The following is a description of a gene set: Mouse Gene Set: MIR_384_5P studied in species Mus musculus from publication Chen Y, Wang X (PMID 31504780) Genes predicted to be targets of miRBase v22 microRNA mmu_miR_384_5p in miRDB v6.0 with MirTarget v4 prediction scores > 80 (high confidence targets)., and this is the list of marker genes: Ifi213, Htr4, Tcaf3, Dnmt3a, Smad1, Ppargc1b, Lox, Pnkd, Gpcpd1, Fnip2, Zfp521, Trappc14, Ssx2ip, Camkk2, Ccdc71l, Gigyf2, Macroh2a1, Ubn2, Ago1, Gnai1 (G protein subunit alpha i1), Rfx7, Rundc3b, Cracdl, Rasgef1a, Ror1, Kctd8, Tcstv2c, Capza1, Csnk1g1, Pdcd5, 0610040J01Rik, E2f7, Arid5b, Bmp5, Gnai2, Kmt2c, Tepsin, Prdm1, Myo5a, Dlgap4, Tmod2, Il21r (NCBI Gene Id 60504), Tnrc6a, Hic2, Zdhhc21, Rnf157, Trip12, Mlxip, Mcf2l, Camk2d, Usp45, Gria2, Sh3rf1, Samd4 (NCBI Gene Id 78475), Pcnx2, Rbm44, Fkbp3, Brd10, Ddah1, Septin7, Tbc1d30, Ankhd1, Cthrc1, Map6, Rad23b (RAD23 homolog B, nucleotide excision repair protein), Sel1l3, Nadk, Gmeb1, Marchf4, Osbpl8, Sall4, Maml1, Sh2b3, Hnrnpul2, Psmd7, Mier3, Hdac9, Ino80d, Frzb, Cdh20, Mfsd6, Dio2, Tdg, Snx33 (NCBI Gene Id 235406), Cadm2, Usp47, Chd1, Rab15, Coq3, Zbtb34, Galnt2, Arhgef6, Kdm3a, Rasa2, B3gnt5, Cacnb2, Rab2b, Cep350, Rap2c, Foxg1, Apaf1, Chd7, Mrpl36, Edc3, Ascc3, Frmpd1, Nedd4l, Tcp11l2, Dgkz, Exo5, Itgbl1, Syngr3, Tecrl, Herc6, Afap1l2, Epc2, Sytl4, Socs3, Hecw1, Ythdf3, Esco1, Slc35f3, Lifr (NCBI Gene Id 319661), Phactr2, Ppp1r12a, Ccn4, Det1, Trp53inp1, Picalm, Shoc2, Tulp4, Vopp1, Cep41, Pbrm1, Man1a2, Dcun1d1, Klf10, Plxnc1, Rapgef2, Nf1, Ntng1, Cep170, Reep3, Proser1, Dock7, Mical1, Zfp36l2, Ap1s2, Dolpp1, Rap1b, Lin7c, Ccdc6, Rgs17, Rnf122, Slc38a2, Map3k12, Sema3a, Dnajc13, Gpr180, Nrk, Desi2, Cyp24a1, Map3k5, Csnk1a1, Six1, Zfp770, Rps6ka5, Nrxn3, Setd5, Dact1, Fosl2 (NCBI Gene Id 14284), Pfn2, Sptssb, Map3k21, Gldc, Ifngr1, Tnrc6c, Rimbp2, Lrrc17 (NCBI Gene Id 74609), Cnot9, Limch1, Cblb, Snai1, Cilk1 (ciliogenesis associated kinase 1), Sox9, Dcbld1, Adra1d, Nsg1, Trpm7, Azin1, Slc4a7, Setd7, Bnip3l (NCBI Gene Id 97931), Pou3f4, Mab21l1 (mab-21-like 1), Dcun1d3, Dennd2c, Sos1, Ddit4, Zfp560, Foxd1, Nfat5, Garre1, Zfp420, Nagpa, Skp2 (NCBI Gene Id 75034), Wipf3, Zfp518a, Septin8, Papola, Zbtb41, Eif5a2, Sec24a, Mat2a, Irs1, Ywhaz, Tasp1, Cpne8, Sema6b, Gatm, Slc35a3, Fam83f, Reep1, Ercc6l2, Tbc1d10b, Jdp2, Actc1, Ednra, Ide, Piezo2, Rnf220, Zcchc2, Zfp644, Jph4, Acvr1, Oga, Tle1, Tia1, Tmem170b, Adamts3, Terb2, Ube2i, Ube3c, Sypl1 (NCBI Gene Id 52577), Fam13c, Chst2, Cul2, Rimklb, Slc15a2, Slc30a4, Zcchc24, Tnxb, Hectd2, Adam19, Prps1l3 (phosphoribosyl pyrophosphate synthetase 1-like 3), Lmbr1l, Fst, Itga8, Mafg, Znrf1, Fam43a, Ptpn21, Larp4, Ell2, Bdp1 (B double prime 1, subunit of RNA polymerase III transcription initiation factor IIIB), Arid1a, Map3k2, Mtdh, Mitd1, Rhebl1, Eed, Spen, Nhlh2, Mttp, Sgk3 (NCBI Gene Id 72422), Wwtr1, Chl1, Ric3, Kras, Zfp507, Xkr4, Vat1, Ppp3r1, Atp6v1c1, Pawr, Abcc9, Fbln5, Capn5, Lonrf1, Foxb1 (forkhead box B1), Gli2, Cadps, Erg, Plch1, Adra2a, Mybl2 (myeloblastosis oncogene-like 2), Hycc2, Pik3cd, Atp6v0d1, Ptp4a1, Ppp3cb, Slc35d3, Lrfn2, Ttll7, Klf8, Cnr1, Elavl4, Eml4, Ncam1, Ark2c, Mboat1, Cdc37l1, Slc7a10, Neurl1b, Zmynd8, Cfap61, Cbfb, Mfsd11 (NCBI Gene Id 69900), Stox2, Chka, Becn1 (beclin 1, autophagy related), Dlgap2, Mmd, Spast, Tcfl5, Scara5, Gna13, Tmem87a, Ppp1r1c, Sdad1, Nlgn1, Meox2, Pptc7, Adam9, Spcs3, Six4, Grm3, Runx2, Aida, Clock, Rps6ka2, Mzt1, Slc38a4, Apba1, Vkorc1l1, Nrg3 (neuregulin 3), Atp2a2, Bcl2l11, Slc12a6, Phtf2, Mfap5, Plekhm3, Pax3, Gabra5, Slc38a7, Lcorl, Rabgap1l, Crkl, Rarg, Myh11 (NCBI Gene Id 99850), Gabrb1, Usp37, Eml1, Cfl2, Ssh2, Bnc1, Erich5, Ptpn13 (NCBI Gene Id 19249), Kcna4, Itpk1, Celf4, Terf1, Twf1, Lpar3, Ado, Yaf2, Pdss1, Ddx19b, Xpo1, Scn3a, Extl2, Rassf10, Ip6k3, Myo9b, Nhsl3, Tent5a, Tbl1xr1, Nt5e, Pcgf5, Rora, Samd8, Lin28a, Slc35f4, Msi2, Ccnjl, Tab3, Ppp2r1b (protein phosphatase 2, regulatory subunit A, beta), Slc7a6, Ypel2 (yippee like 2), Elovl5, Fam91a1, Elavl2, Mkrn3, Fam199x, Abcd2, Gm4871, Usp48, Elmod2, Katnbl1, Rrad, Cpsf6, Smap1, Per2, Pon2, Strip1, Snrpn, Ubn1, Wipf1, Sp4, Rgs8, Cep170b, Lrrc40, Tet1, Bcor, Fbxo45, Nanos1, Ankrd17, Taok1, Exoc6, Zfp608, Flvcr1, Gtf2h4, Nefl, Polr3g, Asah1, Cyb561, Ccnt2, Vmn1r71, 4933409G03Rik, Itgb3, Sec24d, Tmeff1, Ccne2, Lgi1, Zdhhc17, Cth, Psd3, Nfatc3, Pip4k2b, Nedd4, Mast4 (microtubule associated serine/threonine kinase family member 4), Ppargc1a, Gja1, Rasd1, Amotl2, Camk2n1, Pdlim5, Lclat1, Stk39, Ankra2, Lpgat1, Fndc3a, Stac, Polr3e, Gper1, Ppp4r4, Dsg2, Snx18, Carf, Rasa1, Adgra3, Mdm4, Efna3, Tmem121, Dpysl2, Nr5a2, Esyt3, Klhl20, Sema6d (NCBI Gene Id 98780), Gzf1, Klf9, Washc4, Erlin1, Baz2b, Galnt1, Ago3, Lipi, Scn8a, Atg3, Col9a3, Gpt2, Ap4e1, Ppid, Atp2b2, Hbs1l, Sec23a, Sh3pxd2a, Evx2, Camta1, Ube2v2, Tmem200a, Rapgef4, Naaladl2, Prlr, Prickle1, Stx2, Omg, Necap1, Gmeb2, Scn2a, C9orf72, Galnt3, Atosa (NCBI Gene Id 70761), Slc35f1, Lpp, Nr6a1, Galr1, Brd1, Fbxo42, Tfdp1, Prkaa2, Lin28b, Pank3, Arid4a, Calcr, Dsc2 (desmocollin 2), Plxna1, Adamts6, Snx16, Epb41l3, Snapin, Mex3b, Vip, Ccnk, Ttbk1, Sirt1, Bahd1, Slc35c1, Edem3, Usp50, Atg12, Actr1a, Wdr82, Zdhhc20, Pgm1, Calu (NCBI Gene Id 319452), Sgcb, Avl9, Ppp1r18, Fhip2a, Nus1, Ptpn2, Fbxo32, Capn7, Cand1, Lhx8, Cnot6, Gjc2, Jarid2, Rai14, St8sia4, Jade3, Xpr1, Celsr3, Stk35, Col13a1, Ano4, Wdr7, Rab32, Zbtb18, Scn9a, Tnrc6b (NCBI Gene Id 72625), Dgkq, Chst1, Ccdc43, Aox2, Lrrk2, Siah2, Ptgfrn, Rbm46, Jakmip2, Unc5c, Brwd3, Vat1l, Dll4, Mbnl3, Runx1, Slc41a2, Rfx6, Socs1, Kctd7 (NCBI Gene Id 212919), Asb3, A630023A22Rik, Irx4, Bnc2, Scel, Mbtps2, Scn1a, Fzd3, Stxbp5, Edn2, Kcnmb2, Lrp6, Vim, Pip4k2a, Nabp1, Impact, Stag2, Tbc1d15, Nap1l5 (NCBI Gene Id 76305), Galnt7, Srsf7, Haus4, Khnyn, Glcci1, Lamp3, Cdca7, Atxn1 (NCBI Gene Id 97894), Rab23 (NCBI Gene Id 98704), Plagl2, Oxr1, Ap3s1, Etaa1, B4galt6, Ndel1, Large1, R3hdm1, Glce, Plppr4, Tenm3, Slc36a1 (solute carrier family 36 (proton/amino acid symporter), member 1), Epb41, Mier2, Pcdh17, Cop1, Rab38, Ppp3ca, Tent2, Dpy19l1, Hycc1, Ube2j1, Pde7a, Ankrd55, Fign (fidgetin), Ypel5, Plekho2, Cysltr1, Stim2, Dlg5, Tmem181a, Map3k13